Given this list of marker genes NUBP2, CKS2, UBE2G2, IER2, DAXX, NFS1, RAPGEF6, NCBP2, H2AC18, PCM1 (pericentriolar material 1), ATP5F1C, ASH2L, RGL2, NUBP1, CH25H, NFAT5, CNPY2, RECQL5, MAN2A1, PNO1, RBM15B, RRAS, NOL7, XK, CIB1, H2AC17 (H2A clustered histone 17), USP4, PYCR2, SCML2, STYXL1 (NCBI Gene Id 51657), NDUFA1, MAGEF1, NDUFB3, TLL2, PTPN6, CALM2, POLD4, FRY, GPR132, SARS1, SQSTM1, SLC22A4, PTDSS1, ZNF225, RNF7, TRAPPC3, PMVK, SLC2A4, RPL27A, DDX1, RAB8A, H4C13, CAD, IDH3B, MKRN1, ARRB2, TPR, COIL, GNL1, HSF2BP, WDR46, KDM5A, H2BC12L, KEAP1, SLC5A6, KIF15, GSTO1, DLEU2, ZNG1A, RPL5, NDUFB4, DLEU1, HADHB, PLOD3, LAGE3, RLN1, PEX3, NUP88, UBL3 (NCBI Gene Id 5412), CTSC, AKAP10, HLA-A, HMMR, CIAO1, SPAG5, VAPA, ERLIN1, U2AF1, GNPAT, MKLN1, TIMM9, SLC25A40, DBI, BLZF1, PPP3CA, BCKDHA, ZNF142, TCF12, PPP1CB, GINS1, PSMD5, DEF6, RPL32, PLA2G6, TIMM23B, PRKAB1, CSF2RB, POLR3K, MTF1, ASAH1, MAPRE2, MACROH2A1, AP4B1, VPS52, TP53 (NCBI Gene Id 7157), BUD23, PRR3, AIMP2, GNS, NDUFV1, FLOT2, HNRNPL, NCL, RXRB, SCD, RXYLT1, HOOK2, SCAMP3, ENTPD7, PRDX5 (peroxiredoxin 5), TTC33, PDK1, TIMM44, RNF4, BARD1, DPYSL3, PSMD14, TRAP1, CDC6, MAPRE1, RHEB, ARHGEF16, HCFC2, FBXO5, CR2, H2AC14, SYK, PYCR1, UBE2K, PCMT1, ZFPL1, ALDH18A1, TUBG1, EEF1E1, SAP30, TSPY1, MADD, SCLY, NR6A1, GLT8D1, NCBP1, POLR1H, MED20, LY86, STK26, NFKBIB (NFKB inhibitor beta), CUTA, SNRPD3, SRI, ACOX3, GCFC2, RPS17, CLCN2, CACNG3, DDX10, FXR2, PDCD10, IRF3, APBA3, PLA2G15, CDK16, ATM, GPSM3, CYTIP, TYK2, MAP3K5, RRAGA, VDAC2, UBE2D3, METTL1, DBP, M6PR, CALR, HNRNPUL1, CAPZA1, ZNF12, ARID4A, PRPSAP1, MBNL1, BLK, RCL1, STX7, ZNF274, SAE1, SNX5, TRMT13, GGH, DMAP1, CNTN2 (contactin 2), CXXC1, PCF11, CHD1L, BAZ1B, MTF2, UQCR10, DMTF1, KHK, CDC16, MMP8, TMPO, RBM4, MARS1, TMED10, PFN1, SLC12A2, PSMA5, IFNGR1, DDX5, PSMB7, EEA1, MTOR, GATB, H2BC21, PSMA1, VAMP1, MT3, SRSF5, AZIN1, PWP1, JRKL, MAP3K20, LSP1, THRAP3, KPNA3, MRTO4, NACA, TRIM24, TRIB1, RPS6KA5, ZNF410, HSP90B1, MAEA, DCAF11, PPP2CA, PSMD10, AMMECR1, RPS21, CNOT4, AP4M1, PPP2R1B, RAB5IF (NCBI Gene Id 55969), RAB11A, JARID2, PTP4A1, PIGF, P3H1, SRSF2, SAP18, ATP5MC2, BTBD1, PSMD3 (NCBI Gene Id 94019), SUCLG1, H2AC11, LAMTOR5, GDAP1, SH2D3C, TTC4, RNASET2, RPS13 (ribosomal protein S13), PSME3 (NCBI Gene Id 10197), UQCRC2, PTOV1, H4C2, CCT8, ALOXE3, BTN2A1, MOCS2, RECQL, PPP1R7, GTF3C4, ABCC4, NDUFB1, ZNF134, CREB1, CCT7, PPP1R12A, NDUFB5, KCNH4, RPL18, UCHL1, PMS1, LANCL1, HSD17B7, AHCYL1, UBQLN1, RPS19, PTGES3, ATP5F1E, ABI3, PRKAG1, SRSF7, TIMM17A, SLC43A1, H2BC9, PSMB5, ZNF136, MAP4K5, YBX3, PDK2, GMIP, TLE3, H2BC4, TOPBP1, GAK, SLC26A4, HS3ST2, VASP, RAD54L, BIRC6, RPS5, GTF3C5, POLR1B, KIF20A, EXO1, RPS6, SNRPA, CDKN1B, PDE6D, DDX41, ARPC4, RNPS1, EPM2A, SIGMAR1, CCDC6, HDAC6, LSR, CYBA (NCBI Gene Id 1535), MCCC2, CWC27, NDUFA2, TPT1, PMPCB, KIF11, SCO1, NBR2, MKNK1, MAGOH, HNRNPA1, RAP2B, GMDS, AP4E1, DDB1, ATP5F1B, LNPEP, AKAP9, HSPE1, ASB1, DGCR6, MAML1, LZTFL1, SOX12, DRG1, RPL19, NXT1, GLRA3, RABGEF1 (RAB guanine nucleotide exchange factor 1), GALC, IVNS1ABP, NUDT6, FTH1, DNAJA2, PARG, COPS3, SYPL1, PDE4C, NDUFS1, PSMC4, ATXN10, SRP54, HAX1, ENO2, ELL, CRADD, AKR7A2, DMAC2L, ABCB6, EIF3I, CYB561D2, TAGLN2, RPL37, AGPS, SNX15, KIF20B, CSTF3, IER5, CD79B, GNB1L, RAB3GAP2, MBD4, HTRA2 (NCBI Gene Id 27429), SEC61B, TGIF2, TESK2, ERCC6, PPT2, GINS2, RPL27, H2BC8, AMD1, UBXN1, PSMD7, LZTR1 (NCBI Gene Id 8216), ARFIP2, EIF4H, STX16, HEBP1, SREBF2, MYCBP, H2BC11, H2BC6, RPL8, CMAHP, LAMP1, DCTN3, STUB1, IFNAR1, IGBP1, RPL15, LIPT1, SUPT5H, HLA-F (NCBI Gene Id 3134), TNFAIP1, BCKDHB, DYNC1LI1, COX7A2L, H2AZ1, SNX3, VPS29, TULP3, PRMT5, RPL9, TMF1, POLR3G, ADAM22, MTHFD1, KDM5C, MCM5, PREP, RPS26, TIMM8B, TRIM25, WDR4, TMOD2, ZNF286A, EIF4E2, OCIAD1, RPS27L, APPL1, SGPL1, ADGRE5, NUP62, HARS1, ST6GALNAC4 (NCBI Gene Id 27090), DEGS1, ZNF85, PRKAB2, RIGI (RNA sensor RIG-I), PIAS1, NGB, TSC2, ACTR3, H2AC6, COX7C, SPIB, COPS2, MGAT2, PSMD8, MCM3, YIF1A, NBR1, PMS2P3, DPAGT1, DPM2, H2BC7, KHSRP, POLR1D, JMJD7-PLA2G4B, SLC22A3, POU2F1, HMG20A, RPS27A, GABARAP, PPME1, TIMM22, MAT2A, ZKSCAN8, ACSS2, MAT2B, PMM2, CNOT9, GNA12, SERP1, OGA, TRIP13, SNAPC3, CD2AP, RPS6KA2, MMP15, FKBP2, CREBL2, RAD51AP1, SSB, COG5, ABCB10, UXT, CDK6 (cyclin dependent kinase 6), NPRL2, IL17C, DPF1, USO1, RPL31, ARHGEF7, RIPPLY3, METTL13, PHB2, SLC39A8, TRMT6, RPS29, PRKCSH, RAB3A, IFI30, SRSF11, PIGP (phosphatidylinositol glycan anchor biosynthesis class P), HSPA14, FTSJ1 (NCBI Gene Id 4408), PPP6C, POLR1C, SNAPC1, RPLP1, MOCS3, VGF, SRPRA, NDUFS6, RAD9A (RAD9 checkpoint clamp component A), MRPL40, SDF2, AP4S1, PSMG1 (proteasome assembly chaperone 1), RPS6KB1, RPL35, PUDP, SHPK, IPO5, TPP2, FANCF, PTPN1, ZNF593 (NCBI Gene Id 51042, zinc finger protein 593), SCAND1, LATS1, PRKDC, SPTLC2, AIFM1, CD164, ELOA, CEP83, H2AX, NUFIP1, ZNF7, SAV1, PTPA, RRP9, NDUFB6, MPHOSPH6, ERO1A, PTPRF, PEX11B, SERF1B, DPM1, SDF2L1, POMT2, USP11, RBL1, H2AC15, DDX17, SPAG6, THAP12, LDHA, ILK, LSM8, PKM, RASA1, RGS16, SLC39A7, PIAS3, MSH2, RPS25, SOD1, SP4, NAGPA, TMSB4X, TRIM44, CEPT1, PDK3, PEX6, PKN2, GCLC, GPN3, PRKRA, HERC1, ZNF35, CPSF1, SLC25A11, MAP2K7, CDKL3, PCYT1A, RASSF1, GRK4, ATF6, SRP68, SUGT1, GEMIN2, MAFF, MAP2K5, TMEM187, TUBA1B, VCP, PPIA, PFKFB4, FZD5, ZMPSTE24, ANAPC10, NAGA, PALS2, MYBBP1A, CSDE1, RIPK2, CORO1C (NCBI Gene Id 23603), GABPA, ACAD8, ETF1, RPL13, CNDP2, RPS20, CIR1 (NCBI Gene Id 9541), HSPA2, RBBP8, FADS3, CLCN6, FKBP11, MST1R, RIDA, MLX, EIF2S3 (eukaryotic translation initiation factor 2 subunit gamma), CNOT2, ARPP19, PEX16, PER1, DIABLO, TNFRSF21, RSL24D1 (NCBI Gene Id 51187), ATP6V1D, PSMB1, LTA4H (leukotriene A4 hydrolase), TRIM33, ABCE1, ITGB3BP (integrin subunit beta 3 binding protein), USPL1, USP1, GDE1, PA2G4, GOLGA5, NDUFB2, ELOVL1, DDX3X, ZPR1, PSMC5, SEC62, PRPS2, CYTH2, SLC7A1, POLE3, PCNP, ABT1, DCAF8, EIF2S1, H2BC15, RBM39, ING1, MFNG, MFAP1, NR1D1, SMAD3, RFX5, POLH, ZNF174, HSPA9, SMC1A, CDC25B, RAC2, SERTAD1, LSM1, ATG12, CEBPZ, MANF, RANBP3, SRD5A1, EIF3K, ETFA, MT2A, H4C9, ZKSCAN5, CLCN3, YY1, FABP5, MDH1, NME1, RAB1A, SLC39A6, CLN3, H2AC13, H6PD, RNFT1, YWHAH, SLC31A1, UBXN8, ULBP1, ARFRP1, MED17, EFTUD2 (elongation factor Tu GTP binding domain containing 2), XRCC6 (NCBI Gene Id 94359), ATF4 (activating transcription factor 4), MAPK7, NCAPG, RAD50, NUP153, ALKBH1, TSEN34, CACNB1, H2BC10, SLC1A4, PCNA, CACYBP, DCTN4, PPA1, STX10, CBX5, ARL6IP5, DAP3, H2BC14, CISH, DNAI1, OAZ1 (NCBI Gene Id 4946), NDUFA6, NUP54, CUL5, STOM, MAD2L1, ZDHHC3, EPC1, COX15, ARL1, MPC1, POLR3A, SUPT16H, RNF141, here is a description of the gene set: Set 'Myc targets2': targets of c-Myc and Max identified by ChIP on chip in a Burkitt's lymphoma cell line; overlap set. Human Gene Set: BENPORATH_MYC_MAX_TARGETS from publication Ben-Porath I, Thomson MW, Carey VJ, Ge R, Bell GW, Regev A, Weinberg RA (PMID 18443585) Cancer cells possess traits reminiscent of those ascribed to normal stem cells. It is unclear, however, whether these phenotypic similarities reflect the activity of common molecular pathways. Here, we analyze the enrichment patterns of gene sets associated with embryonic stem (ES) cell identity in the expression profiles of various human tumor types. We find that histologically poorly differentiated tumors show preferential overexpression of genes normally enriched in ES cells, combined with preferential repression of Polycomb-regulated genes. Moreover, activation targets of Nanog, Oct4, Sox2 and c-Myc are more frequently overexpressed in poorly differentiated tumors than in well-differentiated tumors. In breast cancers, this ES-like signature is associated with high-grade estrogen receptor (ER)-negative tumors, often of the basal-like subtype, and with poor clinical outcome. The ES signature is also present in poorly differentiated glioblastomas and bladder carcinomas. We identify a subset of ES cell-associated transcription regulators that are highly expressed in poorly differentiated tumors. Our results reveal a previously unknown link between genes associated with ES cell identity and the histopathological traits of tumors and support the possibility that these genes contribute to stem cell-like phenotypes shown by many tumors. species: Homo sapiens